Given this list of marker genes ITM2B, HSPA8, CLDN7, RPL18A, RPL18, RAN (RAN, member RAS oncogene family), SARS1, HLA-G, RPS2, EIF3K, LITAF, SKP1, TMBIM6, DNAJA1, RPS5, TMEM147, SRSF3, RPL21, EIF3G, UQCR11 (NCBI Gene Id 10975), RPL17 (ribosomal protein L17), ODC1, TRIB1, HSP90AB1, FBL, B2M, UBE2E3, ATXN10, RTN4, RPS12, HINT1 (NCBI Gene Id 3094), ATP5F1A, SDC4, ERGIC3, here is a description of the gene set: The demonstration of the PAX8-PPAR(gamma) fusion oncogene in a subset of follicular thyroid tumors provides a new and promising starting point to dissect the molecular genetic events involved in the development of this tumor form. In the present study, we compared the gene expression profiles of follicular thyroid carcinomas (FTCs) bearing a PAX8-PPAR(gamma) fusion against FTCs that lack this fusion. Using unsupervised clustering and multidimensional scaling analyses, we show that FTCs possessing a PAX8-PPAR(gamma) fusion have a highly uniform and distinct gene expression signature that clearly distinguishes them from FTCs without the fusion. The PAX8-PPAR(gamma)(+) FTCs grouped in a defined cluster, where highly ranked genes were mostly associated with signal transduction, cell growth and translation control. Notably, a large number of ribosomal protein and translation-associated genes were concurrently underexpressed in the FTCs with the fusion. Taken together, our findings further support that follicular carcinomas with a PAX8-PPAR(gamma) rearrangement constitute a distinct biological entity. The current data represent one step to elucidate the molecular pathways in the development of FTCs with the specific PAX8-PPAR(gamma) fusion. Human Gene Set: LUI_TARGETS_OF_PAX8_PPARG_FUSION from publication Lui WO, Foukakis T, Lidén J, Thoppe SR, Dwight T, Höög A, Zedenius J, Wallin G, Reimers M, Larsson C (PMID 15608688) Genes down-regulated in follicular thyroid carcinoma (FTC) samples that bear PAX8-PPARG fusion protein. studied in species Homo sapiens